Given this list of marker genes APOBEC3G, CREB3, PARP9, SIN3A (SIN3 transcription regulator family member A), TRIM6, PYCARD, ZDHHC1, LILRB1, IL12RB1, IL23R, ZDHHC11 (zinc finger DHHC-type containing 11), TRIM44, STAT1, TRAF3IP2, IL27, IL12B, ERCC6, MAVS, PML, TOMM70, ZC3H12A, SELENOK, EIF2AK4, DTX3L, RIGI, STING1, TRIM22, HSP90AA1, AIM2, CGAS, APOBEC3F, PQBP1, IL23A (interleukin 23 subunit alpha), here is a description of the gene set: studied in species Homo sapiens Any host process that results in the promotion of antiviral immune response mechanisms, thereby limiting viral replication. Human Gene Set: GOBP_POSITIVE_REGULATION_OF_DEFENSE_RESPONSE_TO_VIRUS_BY_HOST